Given this list of marker genes ADAMTS4, LYVE1, SRPX (NCBI Gene Id 8406), SLCO2A1, LYST (lysosomal trafficking regulator), ACKR1, ICAM1, PRCP, ADAMTS9, NNMT, C7, CADM3-AS1, SELE, IL1R1, PRSS23, SOD2, SOX7, PLA1A, ADGRG6, NCOA7, CSF3, UPP1, VWF, CLU, CPE, VCAM1, PTGDS, NAMPT, FSTL3, TIMP1, TNFAIP3, PLAT, MMRN1, FTH1, CYP1B1 (cytochrome P450 family 1 subfamily B member 1), ABI3BP, CCL23, HDAC9, SELP, CXCL2, here is a description of the gene set: from publication Travaglini KJ, Nabhan AN, Penland L, Sinha R, Gillich A, Sit RV, Chang S, Conley SD, Mori Y, Seita J, Berry GJ, Shrager JB, Metzger RJ, Kuo CS, Neff N, Weissman IL, Quake SR, Krasnow MA (PMID 33208946) Human Gene Set: TRAVAGLINI_LUNG_VEIN_CELL species: Homo sapiens